The following is a description of a gene set: This event has been computationally inferred from an event that has been demonstrated in another species.<p>The inference is based on the homology mapping from PANTHER. Briefly, reactions for which all involved PhysicalEntities (in input, output and catalyst) have a mapped orthologue/paralogue (for complexes at least 75% of components must have a mapping) are inferred to the other species. part of: Plasma lipoprotein remodeling studied in species Mus musculus Reactome Pathway: Chylomicron remodeling electronically inferred by orthology from the curated human pathway, and this is the list of marker genes: Apob, Apoa2, Gpihbp1, Apoa5, Apoc2, Apoe, Lpl, Apoa1, Apoc3, Apoa4